The following is a description of a gene set: studied in species Mus musculus Mouse Gene Set: REACTOME_SLC_MEDIATED_TRANSMEMBRANE_TRANSPORT SLC-mediated transmembrane transport, and this is the list of marker genes: Slc1a3, Slc2a13, Slc1a4 (NCBI Gene Id 55963), Ctns, Ahcyl2, Slc27a6, Slc24a2, Slc27a1, Slc14a2, Slc26a1, Slc28a3, Slc2a9, Slc6a14, Slc26a4, Slco1a4, Slc10a6, Slc6a20a, Slc28a1, Slc17a8, Slc22a8, Slc27a4, Slc29a1, Slc7a10, Slc12a2, Rhbg, Calm1, Slc39a6, Lcn12, Slc35b4, Slc16a1, Slc6a1, Slc7a1, Slc7a8, Slc1a6, Cp, Slc47a1, Slc13a1, Slc5a5, Slc20a2, Slc30a10, Slc11a2, Slc24a4, Slc26a7, Slc31a1, Slc29a2, Slc30a5, Slc26a2, Slc4a2, Slc9a7, Slc5a10, Slc35b3, Calm2, Slc25a26, Slc9a3, Slc6a3, Slc28a2, Slc7a6, Slc43a2, Slc7a7, Slc4a7, Slc4a4, Slc26a6 (solute carrier family 26, member 6), Slc35b2, Slc22a1, Slc35a1 (solute carrier family 35 (CMP-sialic acid transporter), member 1), Slc8a1, Slc22a6, Slc16a3, Slc25a29, Slc1a7, Slc4a8, Slc39a14, Slc2a4, Slc12a7, Slc5a3, Slc1a2, Slc35d1, Sri, Slc2a2, Slc39a8, Heph, Slc12a3, Slc8a3, Slc44a1, Slc4a3, Slc24a5, Slc22a18, Slc26a9, Slc22a16, Slc12a4, Slc25a22, Slc5a11, Slc44a5, Slc9a4, Fgf21, Slc25a4, Slc35d2, Slc38a5, Slc35a3, Slc9a2, Slc8a2, Slc2a7, Slc22a4, Slc1a1, Slc6a7, Slc25a10, Slc5a12, Apod, Slc15a3, Slc25a5, Slc12a6, Slc22a7, Slc43a1, Slc6a19, Slc35c1, Calm3, Arl2bp, Slc2a1, Slc8b1, Slc16a8, Slco4c1, Slc18a1, Slc9a6, Slc6a18, Slc4a5, Slc34a2 (NCBI Gene Id 52185), Slc2a10, Slc16a2, Slc30a1, Slc41a2, Slc5a2, Slc29a3, Slc44a4, Slc50a1, Slc6a12, Slc38a3, Slc36a4, Slc39a2, Slc17a7, Slc2a12, Slc17a1, Slc39a1, Slc45a3, Slc5a6, Bsg, Slc35a2, Slc36a2, Slc20a1, Slc39a7, Slc17a5, Slc26a11, Slc2a6, Slc13a3, Slc22a15, Slc4a10, Slc34a1, Lcn9, Emb, Slc4a1, Slc34a3 (solute carrier family 34 (sodium phosphate), member 3), Slc24a1, Slc44a3, Slco2a1, Slc13a5, Slc2a8, Slc6a2, Slc41a1, Slc38a1 (NCBI Gene Id 105958), Slc3a2, Slc5a8, Slc3a1, Slc9a8, Slc16a7, Slc6a9, Slc7a5, Slc9a5, Slc13a2, Slc25a11, Slc17a6, Slco2b1, Slc5a4a, Slc24a3, Slc6a6, Slc6a15, Slc40a1, Slc25a18, Arl2, Slc39a3, Slc33a1, Slc4a9, Slc9a1, Slc38a2, Slc13a4, Slc7a9, Slc6a13, Slc12a1, Pdzd11, Slc9a9, Slc7a3, Mfsd4b4, Slc6a11, Slc11a1, Rhcg, Slc26a3 (solute carrier family 26, member 3), Slc7a11 (solute carrier family 7 (cationic amino acid transporter, y+ system), member 11), Slc44a2, Slc25a1, Slc2a3, Slc5a9, Slco4a1, Slc16a10, Slc14a1, Slc36a1, Slc5a1, Slc22a12 (NCBI Gene Id 20521), Slco1b2, Slc12a5, Rhag, Slc39a4, Slc15a4, Slc38a4, Slco1c1, Slc5a7, Slc22a3, Slco3a1, Slc22a2, Slc29a4, Slc32a1, Slc22a5, Slc30a8, Slc18a2, Slc1a5, Avp, Slc15a1, Slc6a5